Given this list of marker genes LINC01845, RPL21P57, RNU2-48P, SLC36A1, ITK, RPL6P32, HAVCR2, NDST1-AS1, GRIA1, LINC02227, FNDC9, HNRNPA3P7, MIR1303, RNA5SP199, RPS14, GARIN3, RN7SKP232, RNA5SP198, THG1L, ENSG00000288081, NDST1, CNOT8, LINC01470, ADAM19, ZNF300, ZNF300P1, FABP6-AS1, SPARC, KIF4B, LARP1, MYOZ3, GALNT10, SLC36A2, FAM200C, GPX3, MRPL22, PWWP2A, NIPAL4, RPLP1P6, CLMAT3, FAM114A2, HAVCR1, SYNPO, ATP6V1G1P5, LINC02202, MFAP3, GM2A, RN7SL177P, ADRA1B, ENSG00000254135, NIPAL4-DT, RNU4ATAC2P, SMIM3, HAND1, GAPDHP40, C5orf52, ATOX1-AS1, SLC36A3, MIR1294, RN7SL655P, FAXDC2, FABP6, IL12B, PPP1R2B, LINC01847, PDGFRL2P, ENSG00000300071, MARK2P11, TIMD4, RN7SL803P, PTTG1 (PTTG1 regulator of sister chromatid separation, securin), ENSG00000252458, SLU7, LINC01933, CCNJL, DCTN4, ENSG00000249738, SGCD, SAP30L, CYFIP2, MIR378H (NCBI Gene Id 100616306), LINC01932, SAP30L-AS1, APOOP1, LSM11, ENSG00000275765, LINC01861, NMUR2, MIR6499, MIR3141, TTC1, MIR146A, RNU6-390P, MYOZ3-AS1, TNIP1, GLRA1, RPL36AP20, RNA5SP197, ANXA6, IRGM, RNF145, RNU6-556P, MED7, MIR3142, CD74, C1QTNF2, CIR1P1, UBLCP1, CCDC69, SOX30, MIR3142HG, RBM22, GEMIN5, G3BP1, ATOX1, RNU6-260P, CLINT1 (clathrin interactor 1), EBF1, FAT2, here is a description of the gene set: species: Homo sapiens Human Gene Set: chr5q33